Given this list of marker genes DYNC2I1, CEP164, TCTN1, INVS, CC2D2A, DOCK6, DLL4, RPGRIP1L, NOTCH1, RBPJ, TMEM216, TMEM237, PNPLA6, IQCB1, B9D1, WDR35, EOGT, TRAF3IP1 (NCBI Gene Id 26146), HAMP, TMEM107, SDCCAG8, INPP5E (NCBI Gene Id 56623), NPHP1, TCTN2, TMEM67, NPHP3, PKHD1, TXNDC15, IFT56, MKS1, NPHP4, IFT140, CEP290, ARHGAP31, B9D2, WDR19, HJV, RPGRIP1, CSPP1, TCTN3, DZIP1L, TMEM231, DCDC2, DYNC2I2, DYNC2H1, IFT80, here is a description of the gene set: Human Gene Set: HP_CONGENITAL_HEPATIC_FIBROSIS Congenital hepatic fibrosis The presence of fibrosis of that part of the liver with congenital onset. species: Homo sapiens